The following is a description of a gene set: from publication Elo LL, Järvenpää H, Tuomela S, Raghav S, Ahlfors H, Laurila K, Gupta B, Lund RJ, Tahvanainen J, Hawkins RD, Oresic M, Lähdesmäki H, Rasool O, Rao KV, Aittokallio T, Lahesmaa R (PMID 20620947) Human Gene Set: GSE17974_IL4_AND_ANTI_IL12_VS_UNTREATED_4H_ACT_CD4_TCELL_DN studied in species Homo sapiens The aim of this dataset was to study in detail the transcription kinetics initiated by cytokine IL-4 in early differentiation of Th2 cells. Genes down-regulated in comparison of CD4 T cells treated with IL4 and anti-IL12 at 4 h versus the untreated cells at 4 h., and this is the list of marker genes: TAAR5, FYB2, CRTAM, SERPINB11, IGHM, PI15, KIR2DL5A, LGALS14, SERPINC1, GRIA2, HCN2, GBP5, ZRANB3, PPP1R1C, MAP3K7CL, RADX, DEFA6, LNP1, SCGB1A1, LINC02532, GPR156, PLP2, SCN8A, S100A16, TRNAU1AP, TAS2R8, KRTAP4-4, HSD11B2, IRF4, AGBL1, NTRK2, CSRP3, NPL, LSAMP-AS1, CPNE8, FAM171A2, AK7, NPTX1, JPH1, ZSCAN12P1, ZBED6, ADAM19, PPP1R26-AS1, CHRNA9, TMEM225, PDE7B-AS1, RGS5, ANKRD31, FAR2, NLRP8, BCAR4, PPP1R17, BTBD19, DCAKD, OR51M1 (NCBI Gene Id 79479), RORC, PCDHA3, SRRM4, MRGPRX2, GHRHR, KCNJ15, RASSF4, TDRD3, TRPS1, F3, NR6A1, FLJ30679, DNAI1, ANKRD34A, SLAMF7, BTLA, COLEC10, ESYT3, DDIT4, CRB1, SCEL, RHOH, C18orf21, PCDHB1, AP1S3, KCNK15-AS1, MBLAC1, PIGU, LYPD3, SOST, PCDHGA10, AOX1, C14orf93, LILRA2, ID3, GPC5, PKIG, JMJD8, LGALS4, OR5AK4P, DOCK3, LINC01343, ROPN1, SMIM3, APLP1, TACR3, SLC25A53, PTPRB (protein tyrosine phosphatase receptor type B), UBASH3B, KCNK9, POU2AF3, POLR3G, RNF212B, LINC02871, WNT7A, ARHGAP44, GADD45A, TTC29, LRRC69, IFNA17, ZNF816, TTC23L, MATCAP2, ALG10B, STAG3, PYHIN1, ST8SIA5, PLPP4, TNFRSF8, MTRFR, CD27, GNRHR2, MUC7, GABRA5, WDR38, ABLIM3 (NCBI Gene Id 22885), CCL20, DUSP18, REEP6, RND1, EFHD1 (NCBI Gene Id 80716), SH2D4B, GPR68, WASF3, TAS2R40, IL2, DEPDC1, TNFSF4, C3orf52, GAL3ST4, RRAGB (NCBI Gene Id 10325), GC, SLC4A5, SMTNL2, RBM12B, CD82, PRDM6, HMGB3P22, ADAMTS19, PROSER3, UBE2D4, SLC39A12, PDGFA, PDZK1IP1, ACKR2, FAM171B, PRXL2A, H3C8, MAP4K3-DT, GNG4, SNHG16, BTN1A1, PHF7, LAGE3P1, DUSP4, CCBE1, SNAPC4, ZNF331, CA10, ANXA2P2, KRT84, S100A13, TRAPPC3, EMX2, NNAT, SYDE2, GEM, ITPRIP, GFAP, DCHS2, N6AMT1